The following is a description of a gene set: from publication Chen Y, Wang X (PMID 31504780) studied in species Homo sapiens Human Gene Set: MIR5186 Genes predicted to be targets of miRBase v22 microRNA hsa-miR-5186 in miRDB v6.0 with MirTarget v4 prediction scores > 80 (high confidence targets)., and this is the list of marker genes: PSMA5, ZNF704, EMCN, IMPA2, KLC2, MAP3K21, GLRX, MYOZ2, CCDC85A, EPDR1, TMEM263, C10orf90, TTBK2 (tau tubulin kinase 2), DNAJC12, KCNE2, BEST3, HDAC9, GPR173, FER, INSM1, GGACT, KPNA3, OTUD1, SYT4, EAF1, ATXN7, ARF3, GLI3, ALG11, KCNN3, BRPF3, TRAPPC3L, KBTBD4, ZKSCAN7, CD40LG, NECTIN3, NEXMIF